The following is a description of a gene set: Reactome Pathway: RAF activation This event has been computationally inferred from an event that has been demonstrated in another species.<p>The inference is based on the homology mapping from PANTHER. Briefly, reactions for which all involved PhysicalEntities (in input, output and catalyst) have a mapped orthologue/paralogue (for complexes at least 75% of components must have a mapping) are inferred to the other species. species: Mus musculus electronically inferred by orthology from the curated human pathway part of: RAF/MAP kinase cascade, and this is the list of marker genes: Camk2b, Map2k2, Phb1, Ppp2r5a, Ppp2r1b, Ppp2r5b, Hras, Ppp2r5d, Calm1, Map2k1, Shoc2, Brap